The following is a description of a gene set: Tissue resident memory (Trm) represent a newly described memory T cell population. We have previously characterized a population of Trm that persists within the brain following acute virus infection. Although capable of providing marked protection against a subsequent local challenge, brain Trm do not undergo recall expansion following dissociation from the tissue. Furthermore, these Trm do not depend on the same survival factors as the circulating memory T cell pool as assessed either in vivo or in vitro. To gain greater insight into this population of cells we compared the gene-expression profiles of Trm isolated from the brain to circulating memory T cells isolated from the spleen following an acute virus infection. Trm displayed altered expression of genes involved in chemotaxis, expressed a distinct set of transcription factors and overexpressed several inhibitory receptors. Cumulatively, these data indicates that Trm are a distinct memory T cell population disconnected from the circulating memory T cell pool and displaying a unique molecular signature which likely results in optimal survival and function within their local environment. species: Homo sapiens from publication Wakim LM, Woodward-Davis A, Liu R, Hu Y, Villadangos J, Smyth G, Bevan MJ (PMID 22922816) Human Gene Set: GSE39152_BRAIN_VS_SPLEEN_CD103_NEG_MEMORY_CD8_TCELL_DN Genes down-regulated in memory CD8 T cells, ITGAE- population: brain versus spleen sources., and this is the list of marker genes: MRPL51 (mitochondrial ribosomal protein L51), CBFB, LAPTM4B, HSD17B10, NUP54, TIAM1, ANKRD11, STX12, HIF1A, RBMS1, IKBKG, MAFB, PLSCR1 (NCBI Gene Id 5359), SLC2A1 (solute carrier family 2 member 1), DOK2, HIKESHI, ARPC5L, SLC39A1, THRSP, ALX3, PSMB8, PTPN2, GDAP1, PARN, FYN, JAK2, SCAMP3, CDC34, RAB5C, SLC33A1, FXN, MARCHF5, S100A10, IL4R, SERTAD1, SLC12A4, CBX7, COQ7, ZNF281, NOC4L, SULT1B1, UCK2 (NCBI Gene Id 7371), IL17RA, TOR1AIP2, AHR, BAG3, FBXL5, SF3A3, PDK3, GTF2A2 (NCBI Gene Id 2958), RHOQ, TLE3, SEM1, BYSL, PHF7, RPAP3, ONECUT1, GAB1 (NCBI Gene Id 2549), RARS1, SLC31A1, SLC25A28, TXNRD1, RUNDC3A, ABCE1, RAB12, CXCL10, FCF1, MT2A, FAS, MRPL49, CD164, SEC13, HIVEP2, EML5, LYSMD2, BMP2K, OAS1, BCL6, ETFB, PLA2G4A, HOXC8, CFL2, GPD2, EMP1, PPARD, CRIPT, SLC30A1, CHD7, FCGR2B, RNF19B, TRA2B, BACH1, WDR77 (WD repeat domain 77, NCBI Gene Id 79084), DMP1, CA4, S100A11, ORMDL2, RNH1, GJA1, MRPL21, RCN1, ATP1A1, PRRC1, STAR, YIF1A, ARL5A, MRPL20, CXXC5, SLIRP, C6orf136, HOXA1, TIMM13, GPR12, AGFG1, CASP4, UGCG, CLDND1, MFF, EIF6, NMD3, RBM8A, LPP, PTPN1, EXOSC10, NSMCE1, CYP51A1, CHRAC1, CASP1, YME1L1, CDK8, DNAAF10, DUSP1, GUCA1A, BZW2, PIM1, CLIC4, ADPRS, ACOD1, MDH2, HOXA13, MCOLN2, LSM4, BCAS2, SUSD6, ST3GAL4, PFDN6, SNX5, PSME2, SRI, COMMD2, EXT1, MIX23, GADD45G, RASGRP2 (RAS guanyl releasing protein 2), RNF34, NOTCH1, CSF2RB, PLGRKT, STAT1, ZFP64, ICAM1, MRPL16, CEBPB, IL18BP, BCL2L1, R3HDM1 (NCBI Gene Id 23518), AMFR, MRPL52, TBCA, CCL4, NOLC1, FBXW11, TMEM167A, TSPAN4, MIS18A, RRS1, MRPL33, AMBP, TGFBI, BRIX1, CDKN2D, EIF1AY, IL13RA1, CGA, VRK1, C9orf85, GBP7, PDCD5, PSMA7, U2SURP, SKA2, SRGN, NOP58, PSMD13, ATF3, OTUD4, EN1, PSMD4, SLC12A7, CD34